The following is a description of a gene set: Human Gene Set: MORF_ATOX1 species: Homo sapiens Neighborhood of ATOX1 ATX1 antioxidant protein 1 homolog (yeast) in the MORF expression compendium Neighborhood of ATOX1, and this is the list of marker genes: ETFA, CSTB, UQCRB, VTI1B, SLC25A1, CNIH1, ATP6V1H (NCBI Gene Id 51606), PSMD8, TBCA, HSBP1, COX5A, GGCT, SEC61G, MYL11, MORF4L2, ELOB, UBA1, ATP6V1F, PDCD6, SHMT1, BCAP31, BUD31, RAB9A, ARF5, PPP1R7 (protein phosphatase 1 regulatory subunit 7), PSMB4, NEDD8, EIF2B2, FAM20B, PSMB2, TMEM147, PTPA, COA1, RAC1, YWHAB, PRKAR1A, DPM1, AP2M1, DCTN2, PSMC4, SEM1, PLOD3, KARS1, ATP5MF, COPS5 (COP9 signalosome subunit 5), TMBIM6, SARS1, ATOX1, SOD1, BANF1, SDHC, CANX, CNPY2, RER1, PRMT1, ENSA, AP2S1, POLR2H, PSMA3, CFDP1, SEPHS2 (NCBI Gene Id 339090), TMED2, CLN3, DYNC1I2, EIF4E2, GMFB, RAD23B, SUMO1, PSMD7, ALG8, RAB1A, PSMC1, CENPB, DNPEP, SNRPG, RAB5A, PSMB6 (NCBI Gene Id 95505), HARS2, PSMB5 (NCBI Gene Id 5693), PGRMC1